Given this list of marker genes CD274, RBX1, YWHAG (NCBI Gene Id 96443), CSNK2A1, PSMD6, CCND1, SEM1, PSMA5, PSMD14, CDK4, PSMD3, PSMC3, PSMD11, PSMB3, PSMC4, PSMB1, CSNK2A2, RPS27A, UBC, PSMA1, PSMC2, PSMA6, PSMB4, PSMA2, PSMD7, PSMA7, PSMD2, CUL3, PSMD13, PSMB6, PSMC5, UBA52, PSMD8, PSMA3, PSMD12, PSMD1, PSMA4, UBB, CSNK2B, PSMC1, PSMB2, SPOP, ADRM1, PSMB5, PSMB7, PSMC6, here is a description of the gene set: part of: Regulation of PD-L1(CD274) Post-translational modification studied in species Homo sapiens SPOP:CUL3:RBX1 E3 ubiquitin ligase complex regulates the ubiquitination and degradation of PD-L1(CD274) protein. This is negatively regulated by Cyclin D:CDK4 complex which phosphorylates SPOP on Ser-6 (S6) and facilitates its sequestration by 14-3-3 protein gamma, thus inhibiting SPOP-mediated recruitment in the E3 ubiquitin ligase complex. Reactome Pathway: SPOP-mediated proteasomal degradation of PD-L1(CD274)